Given this list of marker genes KDM3A, ZNF146, CWC15, DLL3, USP44, VN2R3P, ZNF565, SLC33A1, GGA2, CHCT1, NRAL, MTCO3P12, ADI1P3, ETFBKMT, TERF1P6, MTND5P11, ZNF780A, RAI14, GLUD1P3, S100PBP, POLD1 (NCBI Gene Id 5424), RPL22P17, TMEM192, BMS1P4, DCLK1, BMS1P4-AGAP5, CNN2, DUSP8P5, NAPSB, NBPF1, RNU6-1243P, here is a description of the gene set: species: Homo sapiens Genes containing one or more binding sites for (ZNF354A) in their promoter regions (TSS -1000,+100 bp) as identified by GTRD version 20.06 ChIP-seq harmonization. from publication Yevshin I, Sharipov R, Kolmykov S, Kondrakhin Y, Kolpakov F (PMID 30445619) Human Gene Set: ZNF354A_TARGET_GENES